Given this list of marker genes Sptbn4, Dlg4, Epb41l3, Kcnab1, Lgi3, Cntn2, Dlg2, Kcnab2, Kcna2, Cntnap2, Sirt2, Kcna1, here is a description of the gene set: A region of an axon near a node of Ranvier that is between the paranode and internode regions. Mouse Gene Set: GOCC_JUXTAPARANODE_REGION_OF_AXON studied in species Mus musculus